The following is a description of a gene set: The series of molecular signals initiated by an extracellular adrenomedullin combining with a dimeric adrenomedullin receptor on the surface of the target cell. Human Gene Set: GOBP_ADRENOMEDULLIN_RECEPTOR_SIGNALING_PATHWAY species: Homo sapiens, and this is the list of marker genes: CALCRL, RAMP3, ADM2, ADM, RAMP2